The following is a description of a gene set: The beginning of development of the breasts in the female. studied in species Mus musculus Mouse Gene Set: GOBP_THELARCHE, and this is the list of marker genes: Ncoa3, Med1, Tgfb1, Areg (NCBI Gene Id 11839), Phb2, Wnt5a